Given this list of marker genes STK11IP, WFS1, SEPTIN12, HNRNPF (heterogeneous nuclear ribonucleoprotein F), IGSF1, COP1, NOVA2, HOXB3, SLC6A10P, DDX17, C19orf47, FMOD, STC2, ZNF367, ZNF362, PAFAH1B1, KLF5, GRIA3, GNAS, RGN, LTBP1, PEX16, MSN, MTRFR (NCBI Gene Id 91574), GCNT2, DACT1, YPEL1, GRK2, PRDM12, RAB4B, TOX2, GMPR2, FYN, KRTAP17-1, HOXB4, BHLHE22, ADAMTS3, MB, LRFN5, B3GALT2, MAP4K4, NXPH1, ZNF800, CLDN8, GCAT, TTC16, TPP2, CDK17, NOTCH2, NEUROD6, IL11RA, GTF3C2, RHOA, LRCH4, FSTL5, SLC39A4, TNS2, AGBL5, ZNF746, FEZF2, HOXC6, CHRDL1, CNTD1, S1PR2, PCDH9, TMEM62, FBXL2, SPAG9, CDH13, ESRRG, DLX1, MAEL, PRPF38B, ARHGAP12, MED13, JADE1, ODF2, FBXO24, MYO18A, USP5, CAPZA1, DOCK1, ANKRD28, CHN1, ASPA (NCBI Gene Id 443), UGGT1, SESN3, P2RY2, CD44, DNAH12, YWHAE, SEMA7A (NCBI Gene Id 8482), MICAL2, SLC16A6, CSAD, NOTCH2NLA, UBE2H, MYL6B, JARID2, SSBP2, FLI1, MAP1S, SDC1, PREB, NKAIN1, FAM181A, TOR1AIP1, KIF7, TMEM60, PHF7, KMT2E, SOCS2, BAP1, TGM5, CITED2, PTPN22, SYVN1, FRAS1, GYG1, RHOC, ID4, RAB3C, FGF16, PPP4R4, PRUNE1, TCTA, ABHD15, WDR81, NR6A1 (NCBI Gene Id 2649), FUT11, ALDOA, SMCO4, CFAP69, RHOV, KCNK7, ADAM2, SPOCK2 (SPARC (osteonectin), cwcv and kazal like domains proteoglycan 2), FCGBP, MTERF2, IVL, DDR2, TMEM69, CRISPLD1, MDGA2, HHEX, SKIDA1, SPATA8, ZYX, ING3, STC1 (stanniocalcin 1), RUNX1T1, REPS1, HOXB5, TFAP2C, TYSND1, MLN, KMT2A, CACNA1G, MFSD5, FBXL14, BEND4, ODF4, ARHGEF6, MAP4, PRICKLE1, CDCA3, HES6, OTX1, TMEM97, TUG1, ADGRG4, TNNI1, CACNB2, SNRPD1, KMT5A, HNRNPUL1, NKX2-8, AK2, COA3, BSCL2, PIP4K2B, HEPACAM, GABPB2, MBD6, GNG3, EIF4G2, CNTF, AKR1A1, GRIN2A, CDK2, RFX4, KRT14, RIN1, DLG3, RCAN2, VN1R3, PMEL, NR3C2, DLGAP1, PCSK1N, PABPC1, NOL4L, TLE3, CAMK2A, FAF2, MDM1, TMEM35A, NEDD8, ALOX12B, PABPC3, ZNF767P, SHKBP1, CD5, MNT, HOXB8, IER5L, KMT2D, GNAT1, ST7L, RAPSN, EPB41, C6, MINDY1, IGFBP4 (NCBI Gene Id 3487), SRSF8, KDM6A, RPRD2, KRT25, RARG, ANKRD17, ANK2, JPH3, MGLL, OSR1, WDR86, PFN2, MBD3, TRPC1, UBE2S, MIR22HG, WDR82, FGF12, BDNF, PHC1, CDK14 (cyclin dependent kinase 14), ZBTB32, SYNPO, ONECUT1, VCPKMT, SOBP, SLC9A7, HOXA3, TP53I13, LNPEP, ID3, PNMA1, HTN1, here is a description of the gene set: species: Homo sapiens Human Gene Set: MYB_Q6 Genes having at least one occurrence of the motif NNNAACTGNC in the regions spanning 4 kb centered on their transcription starting sites. This matches the MYB transcription factor binding site V$MYB_Q6 (v7.4 TRANSFAC).